Given this list of marker genes TNFRSF13B, UBE2N, CAPZB, HOPX, CXCR3, PTPN1, CD99, IGFLR1, AIM2, S100A4, CAPG, GSTK1, EVI2B, NEAT1, LSP1, BHLHE41, S100A10, CRIP1, VIM, GRN, SCIMP (NCBI Gene Id 388325), BLK, CTSH, S100A11, S100A6, SRGN, CLECL1P, ISCU, SUB1, RGCC, FCRL5, ARPC1B, PLEK, EMP3, RGS1, CCDC50, PLP2, ACP5, GPR183, CD27, ANXA2, LGALS1, ITGB1, ENTPD1, CD86, COTL1, IFI30, CD82, IGHA1, HCST, here is a description of the gene set: studied in species Homo sapiens Genes upregulated in subsets of cells of a given type within various tumors In this study, an extensive analysis was conducted to define meta-programs (MPs) capturing intra-tumor heterogeneity across a spectrum of tumor types. The approach utilized non-negative matrix factorization (NMF) to analyze each cell type separately within individual tumor samples. This involved the analysis of malignant cells, macrophages, fibroblasts, endothelial cells, epithelial cells, T-cells, and B-cells. NMF was executed with varying parameter values (K=4, 5, 6, 7, 8, 9), thereby generating 39 programs for each cell type per sample. Each NMF program was summarized by the top genes based on NMF coefficients.\nRobust MPs were then delineated for each cell type using a set of stringent criteria, including recurrence within the same tumor, similarity to programs in other tumors, and non-redundancy within a tumor. Subsequently, these robust NMF programs were clustered (per cell type) based on Jaccard similarity, leading to the identification of MPs associated with each cell type.\nTo enhance the quality of the MPs, a refinement steps were undertaken, involving the removal of MPs suspected of reflecting low-quality data (with an overrepresentation of ribosomal proteins or mitochondrial-encoded genes), single-study inclusion, or similarity to miss-annotated cell types. Human Gene Set: GAVISH_3CA_METAPROGRAM_B_CELLS_MEMORY from publication Gavish A, Tyler M, Greenwald AC, Hoefflin R, Simkin D, Tschernichovsky R, Galili Darnell N, Somech E, Barbolin C, Antman T, Kovarsky D, Barrett T, Gonzalez Castro LN, Halder D, Chanoch-Myers R, Laffy J, Mints M, Wider A, Tal R, Spitzer A, Hara T, Raitses-Gurevich M, Stossel C, Golan T, Tirosh A, Suvà ML, Puram SV, Tirosh I (PMID 37258682)